Given this list of marker genes Cap1, Atrx, Gpc6, Nrn1, Atp9a, Ppp1r3c, Ptk7, Loxl2, Slc27a3, Tubb2b, H4c1, Sema3b, Ago2, Plekhg1 (NCBI Gene Id 52522), Rgs4 (NCBI Gene Id 19736), Map1b, Kdm5a, Marf1, Fat4, Rgs17, Pfn1, Cpd, Cdo1, Pax1, Peg3, Dpysl4 (NCBI Gene Id 27016), Chodl, Tmtc4, Nfia, Myh11, Slc12a2, Mpped2, Golga4, Malat1, Nfib, Thoc2, Fgfr2, Cadm4, Akap9, Map3k2, Cdkn1c, Ctsf, St3gal5, Camk2d, Npr3, Grpr, Snx18, Tinagl1, Sesn3, Tspan5, 6330403K07Rik, Snapc3, Igf2, Hnrnpl, Cyp39a1, Perp, Gnb1, Endod1, Slc14a1, Hmga2, Ino80d, Cul5, Crebbp, Selenbp1, Atp1b1, Zcchc24, Nnat, Parm1, Cenpe, Angpt4, Rcor3, Net1, Col3a1, Col2a1, Pth1r, Tpr, Ifi44, Pik3r1, Mybl1, Pcsk5, Hsd17b11, Cbl, Sptbn1, Msi2, Foxa1, 2610005L07Rik, Rora, Garin5b, Arglu1, Mcpt8, Sox2, Rictor, Rbfox2, Cacna1h, Pcx, Rc3h2, Luzp1, Cd14, Ankrd11, Sncg, Srpk2, Atxn2 (ataxin 2), Tpm1, Gpc3, Tnpo2, Rgs5, Resf1, Igf2r, Wnt5a, Ddx6, Clca3a1, Rian, here is a description of the gene set: Genes down-regulated after 1 h of TGFB1 stimulation in MEF cells (embryonic fibroblast) with NFIC knockout vs wild type MEFs. from publication Plasari G, Calabrese A, Dusserre Y, Gronostajski RM, McNair A, Michalik L, Mermod N (PMID 19752192) species: Mus musculus Transforming growth factor beta (TGF-beta) and platelet-derived growth factor A (PDGFAlpha) play a central role in tissue morphogenesis and repair, but their interplay remain poorly understood. The nuclear factor I C (NFI-C) transcription factor has been implicated in TGF-beta signaling, extracellular matrix deposition, and skin appendage pathologies, but a potential role in skin morphogenesis or healing had not been assessed. To evaluate this possibility, we performed a global gene expression analysis in NFI-C(-/-) and wild-type embryonic primary murine fibroblasts. This indicated that NFI-C acts mostly to repress gene expression in response to TGF-beta1. Misregulated genes were prominently overrepresented by regulators of connective tissue inflammation and repair. In vivo skin healing revealed a faster inflammatory stage and wound closure in NFI-C(-/-) mice. Expression of PDGFA and PDGF-receptor alpha were increased in wounds of NFI-C(-/-) mice, explaining the early recruitment of macrophages and fibroblasts. Differentiation of fibroblasts to contractile myofibroblasts was also elevated, providing a rationale for faster wound closure. Taken together with the role of TGF-beta in myofibroblast differentiation, our results imply a central role of NFI-C in the interplay of the two signaling pathways and in regulation of the progression of tissue regeneration. Mouse Gene Set: PLASARI_TGFB1_SIGNALING_VIA_NFIC_1HR_DN